Given this list of marker genes HMGCS2, AKT2, GLYCTK, LMNA, DOLK, ACADVL, HADH, here is a description of the gene set: species: Homo sapiens Human Gene Set: HP_INCREASED_CIRCULATING_FREE_FATTY_ACID_LEVEL A higher than normal levels of the fatty acids which can occur in plasma as a result of lipolysis in adipose tissue or when plasma triacyglycerols are taken into tissues. Increased circulating free fatty acid level